The following is a description of a gene set: Mouse Gene Set: GOMF_CARBOXYPEPTIDASE_ACTIVITY studied in species Mus musculus Catalysis of the hydrolysis of a single C-terminal amino acid residue from a polypeptide chain., and this is the list of marker genes: Naalad2, Cpb2, Cpxm1, Cpq, Agbl2, Vash2, Cpa6, Agtpbp1, Prep, Lap3, Cpb1, Cndp2, Scpep1, Cpxm2, Folh1, Cpe, Matcap1, Mme, Matcap2, Mindy1, Cpa4, Cpa1, Agbl4, Ctsa, Cpn1, Agbl3, Vash1, Ace2, Agbl1, Aebp1, Ace, Ctsl, Naaladl1, Agbl5 (NCBI Gene Id 231093), Cpa5, Cndp1, Cpvl, Cpd, Ctsz, Mindy2, Cpa3, Cpm, Cpz, Cpa2, Pm20d2, Prcp